Given this list of marker genes RPL23A (ribosomal protein L23a), RPLP1, RPL21, RPL39, RPL30, UBA52, RPL13A, RPL19, RPS18, RPS23, RPL31, EEF1G, RPL27, RPL12, RPL37, RPS14, RPS6, RPS10, RPL23, RPS2, RPS12, RPS17, EEF1A1, RPS24, RPL41, RPL27A, RPS27, RPL10, RPL37A, RPL32, RPS3A, RPS11 (NCBI Gene Id 6205), RPS13, RPS20, RPL9, TPT1, RPL38, RPS4X, here is a description of the gene set: Neighborhood of TPT1 Human Gene Set: GNF2_TPT1 species: Homo sapiens Neighborhood of TPT1 tumor protein, translationally-controlled 1 in the GNF2 expression compendium